Given this list of marker genes DLX4, DEAF1, IRF6, MYMX, RAI1, SIAH1, TP63, ERI1, THOC6, COBLL1, RAD21, MSX1, DGCR8, DGCR6, TUBB6, NECTIN1, TWIST2, TBX1, ARHGEF38, SF3B4 (splicing factor 3b subunit 4), BMP4, FLII, TWIST1, CDH1, DLG1, BICRA, ESS2, DGCR2, RIC1, ARHGAP29, PDGFRA, RLIM, GRHL3, NEK1, IQSEC2, UBB, SMAD4, here is a description of the gene set: Velopharyngeal insufficiency species: Homo sapiens Human Gene Set: HP_VELOPHARYNGEAL_INSUFFICIENCY Inability of velopharyngeal sphincter to sufficiently separate the nasal cavity from the oral cavity during speech.